The following is a description of a gene set: studied in species Homo sapiens Human Gene Set: chr7q11, and this is the list of marker genes: LIMK1, CCL24, METTL27, SNORA14A (small nucleolar RNA, H/ACA box 14A), STYXL1, NSUN5P1, GTF2IP1, INTS4P2, TMEM270, ZNF733P, MIR4650-1, GABPAP, MIR3914-1, TYW1B, FZD9, VPS37D, RNA5SP233, STAG3L2, ZNF679 (NCBI Gene Id 168417), GTF2IP23, RNU6-1254P, SEPTIN14P1, MTND2P4, BUD23, FKBP6P1 (FKBP6 pseudogene 1), PMS2P4, GTF2I-AS1, ENSG00000232817, ZNF138, LINC00174, MTDHP1, GTF2IP14, TBL2, SBDS, FDPSP2, SKP1P1, STX1A, MTATP6P18, ASL, RNU6-832P, INTS4P1, CT66 (cancer/testis associated transcript 66), POM121, RPL7AP43, CCT6P1, FKBP6, GTF2IRD2P1, RNA5SP231, MIR4283-2, MTND4LP2, TRIM60P17 (tripartite motif containing 60 pseudogene 17), FPASL, ZNF734P, CLDN4, SPDYE12, MLXIPL, MTND4P2, RNU6-1198P, TMEM60, PMS2P10, PMS2P9, ENSG00000306183, GTF2IRD1, RABGEF1P3 (RABGEF1 pseudogene 3), ABCF2P2, ELN, MIR3914-2, PMS2P8, CICP24, RABGEF1P1, UPK3B, YWHAG, GTF2IP9, TYW1, LINC02848, TRIM50, MTCO2P25, PHKG1P2, SPDYE8, GTF2I, ZP3, SPDYE16, SLC25A1P3, MTND1P2, HSPB1, BNIP3P11, CCDC146, SPDYE21, SPDYE14, SNORA15B-2, PHTF2, PMS2P3, CCT6P3, SBDSP1, RNU6-313P, VN1R40P, POMZP3, RN7SL265P, ENSG00000199231 (NCBI Gene Id 124901826), SEPHS1P1, RNU6-912P, SSC4D, GTF2IRD1P1, VN1R33P, RNU6-417P, TMEM248, MTCO2P8, MIR4284, LINC03011, RPL7L1P3, TNRC18P2, TMEM120A, MIR4651, SEPTIN7P5, UPK3BP1, GTF2IRD2, SEPTIN7P4, TRIM74, RABGEF1P2, SRRM3, VN1R31P, RN7SL43P (RNA, 7SL, cytoplasmic 43, pseudogene), SPDYE13, RN7SKP75, ZNF735, BNIP3P44, SPDYE17, BNIP3P42, SLC29A4P2, MTCO1P25, HNRNPCP7, ZNF107 (zinc finger protein 107), RPL6P20, SNORA22C, ZNF722, POM121B, NSUN5P2, ZNF90P3, CRCP, PMS2P14, GTF2IP7, RPL31P38, RABGEF1, RNU6-229P, SPDYE18, PMS2P7, PMS2P6, SPDYE11, PHB1P15, TPST1, VN1R32P, RPL35P5, ENSG00000189316, ZNF92, MDH2, MIR6839, SAPCD2P1, PPIAP81, FDPSP7, NCF1, CALN1, ENSG00000225718, MIR4650-2, ENSG00000226829 (NCBI Gene Id 105375341), CLDN3, PHKG1P1, RNA5SP232, RNU6-863P, PMS2P13, VN1R34P, NCF1B, RPL7AP77 (ribosomal protein L7a pseudogene 77), ENSG00000296880, TRIM73, RFC2, FAM185BP, MTCO3P41, GUSB, LINC03075, EEF1DP4, MTCO3P8, TRIM60P18, LAT2, BAZ1B, VN1R42P, SPDYE7P, ZNF736, GCNT1P5 (NCBI Gene Id 100421598), RHBDD2, RCC1L, CCL26, VN1R37P, ABHD11, RNU6-1080P, ZNF273, ZNF680 (zinc finger protein 680), MIR590, ELN-AS1 (NCBI Gene Id 107986809), LINC03009, GTF2IP5, PMS2P2, STAG3L4, ARAFP3, RN7SL625P, APTR, FKBP6P2, PTPN12, CLIP2, RN7SL377P, RNU6-1229P, NMD3P1, VN1R36P, PMS2P11, NCF1C, SAPCD2P3, GALNT17, PHB1P6, MTATP6P21, SNORA22, SLC25A1P2, GTF2IP4, GUSBP6, VN1R35P, MTND4P3, ERV3-1, SNORA15B-1, MTND3P2, EIF4H, ZNF727, NUPR2P1, YWHAEP1, SPDYE5, POR, DTX2, GSAP, PMS2P5, DTX2P1, VN1R38P, SAPCD2P4, ZNF117, RNU6-973P, STAG3L3, BICDL3P, SPDYE9, RSL24D1P3, LINC03129, LINC01005, FGL2, VKORC1L1, GTF2IRD2B, RSBN1L, ENSG00000233689, MTCO1P57, LINC02604, NSUN5, SPDYE10, ENSG00000305531, POM121C (POM121 transmembrane nucleoporin C), LINC03006, DNAJC30, PHB1P5, BCL7B, HIP1, KCTD7, AUTS2, ARAFP1, CASTOR2, ENSG00000234387 (NCBI Gene Id 124901641), ARAFP2, DTX2P1-UPK3BP1-PMS2P11, SPDYE15, ZNF680P1, STAG3L1, MTCO1P8